The following is a description of a gene set: species: Homo sapiens Cellular response to mitochondrial stress Human Gene Set: REACTOME_CELLULAR_RESPONSE_TO_MITOCHONDRIAL_STRESS, and this is the list of marker genes: EIF2S1, EIF2S3, OMA1, YME1L1, EIF2AK1, PHB2, EIF2S2, STOML2, DELE1